Given this list of marker genes EIF2S3, ITPRID2, TLK1, ALOX5, ERAP2, FUBP1, BRD1, RTF1, SPG11 (NCBI Gene Id 80208), ERAP1, DYNC1LI1, HDGFL3 (HDGF like 3), ZSCAN32, PRKAB1, ETNK1, AHCYL1, ATP6V1A, ZFX, NFYC, FLOT1, UBR5, ITPR2, MAFF, ICAM1, TMEM259, CASP9, ZNF665, here is a description of the gene set: studied in species Homo sapiens Human Gene Set: NICK_RESPONSE_TO_PROC_TREATMENT_DN from publication Nick JA, Coldren CD, Geraci MW, Poch KR, Fouty BW, O'Brien J, Gruber M, Zarini S, Murphy RC, Kuhn K, Richter D, Kast KR, Abraham E (PMID 15339848) Genes down-regulated in neutrophils upon treatment with activated protein C (PROC) of pulmonary inflammation induced by bacterial lipopolysaccharide (LPS). Recombinant human activated protein C (rhAPC) is a natural anticoagulant with potentially important anti-inflammatory properties. In humans with severe sepsis, rhAPC treatment reduces mortality, but mechanisms responsible have not been well characterized. Accumulation of activated neutrophils in the lungs and other organs during severe infection contributes to sepsis-induced organ dysfunction, including acute inflammatory lung injury. Because neutrophils express an APC receptor, we hypothesized that immunomodulatory effects of rhAPC occur, in part, via modulation of neutrophil responses. To examine this issue, we performed a double-blinded, placebo-controlled study of rhAPC in a human model of endotoxin-induced pulmonary inflammation. Administration of rhAPC significantly reduced leukocyte accumulation to the airspaces, independent of pulmonary cytokine or chemokine release. Neutrophils recovered from bronchoalveolar lavage fluid of volunteers receiving rhAPC demonstrated decreased chemotaxis ex vivo. Decreased neutrophil chemotaxis following exposure to rhAPC was confirmed in vitro. No differences were detected in gene expression, kinase activation, cytokine release, cell survival, or apoptosis of neutrophils recovered in the presence or absence of rhAPC. These studies demonstrate that rhAPC reduces both endotoxin-induced accumulation of leukocytes in the airspaces and neutrophil chemotaxis. These rhAPC-induced effects on neutrophil function may represent a mechanism by which rhAPC improves survival in patients with sepsis.